Given this list of marker genes CHCHD4, MRPL57, RFC3, POLR1B, SMS, MTM1, DNAJC24, NUP155, ACY1, HARS1, GATC, EXOSC9, PELP1, DTWD2, THOP1, NASP, VIL1, PDLIM1, AGTR1, SDF2L1, FASTKD2, MTFR2, NEFH, SNF8, HYPK, ZNHIT6, NDUFA12, DOLK, HYKK, CFAP20, RRS1, STOML2, MRPL35, PRPF19, RANBP1, TMEM100, QTRT2, TMEM151A, PDSS2, GTPBP4, NR4A2, RIOX1, SFPQ, LY6G6C, ST3GAL5, GLRX5, NLRP9, MTRR, MPV17L, EXOSC3, ZDHHC16, DDX18, CCR1, INTS5, MAP3K20, PSMG2, SSC4D, TIGAR, PWP1, TTLL12, CEP83, HMGA2, MTARC2, NDUFB6, WDR55 (WD repeat domain 55), NEU2, VTCN1, SRPRA, DEPDC1B, PTCD3, RD3, CD34, CAMKK2, DNAI3, MRPL11, PRKAR2A, HSF1, COQ4, HSPD1, PFDN2, MAK16, MAP2K2, ALKBH1, PEX14, UGGT2, BANF1, C10orf88, BATF2, RBM14, LYAR (NCBI Gene Id 55646), SAMM50, IGKC, COPS7A, ABT1, NCBP2, PTRH2, MCM5, KIRREL3, PADI4, ERF, SLC38A1, LRR1, ETV6, XKR5, EIF5A, GPR183, DNAH2, NDC80 (NDC80 kinetochore complex component), MPHOSPH10, CDCA5, LRRN4CL, TSR3, PUS7, MPV17L2, PRSS27, CFB, KCTD7, OTP, MIXL1, NSUN2, FH, NUDC, CC2D2A, PATZ1 (POZ/BTB and AT hook containing zinc finger 1), KTI12, SRSF1, NUP133, AGBL3, DUS1L, PPIH, RBFA, NDUFAF4, MOCS3, CAD, RRN3, EXO1, C1QBP, TMA7 (translation machinery associated 7 homolog), RSL24D1, FIGNL1, DHX37, URB2, CD40LG, ADAMTS20, NRROS, TIPIN, DAPL1, DERL2, PPIA, GEMIN6, HAUS2, MYOM3, ACTG1, CALB1, CASP4, GTF2F1, PUM3, DIAPH3, BCLAF1, STRAP, E2F6, MRPS35, HTR3A, RPF1, RRP15, KCNAB1, LAP3, TACC3, SRSF7, WDR3, NUF2, NUP37, MTFP1, PARS2, SKIC8, SMR3A, SCARA5, SELENOI, KRTAP2-4, CTPS1, H2BC18, TRIM37, SLAMF8, FAM174C, CCNE1, MRPL21, HLCS, TRPC3, TIMM8A, SUGP1, HOXA7, SPRR2F, CISD2, FCER2, CCNYL1, TMEM229B, MAGOHB, here is a description of the gene set: Genes down-regulated in B lymphocytes: naïve versus germinal center. from publication Luckey CJ, Bhattacharya D, Goldrath AW, Weissman IL, Benoist C, Mathis D (PMID 16492737) In order to better understand the factors that regulate B cell differentiation upon exposure to antigen, we compares global gene expression profiles from naive B cells with antigen-specific plasma, germinal center, and memory B cells after immunization with the T-dependent antigen, NP-CGG. The memory B cell-enriched transcripts were then compared with memory T cell-enriched and hematopoietic stem cell-enriched transcripts in order to generate a transcriptional profile of self-renewal within the hematopoietic system. Human Gene Set: GSE4142_NAIVE_VS_GC_BCELL_DN studied in species Homo sapiens